The following is a description of a gene set: Ketotic hypoglycemia Low blood glucose is accompanied by elevated levels of ketone bodies in the body. Human Gene Set: HP_KETOTIC_HYPOGLYCEMIA species: Homo sapiens, and this is the list of marker genes: NNT, HNF1A, MRAP (melanocortin 2 receptor accessory protein), ACADS, MRPL39, GYS2, TXNRD2 (NCBI Gene Id 10587), PHKB, MC2R (melanocortin 2 receptor), SLC16A1, STAR (steroidogenic acute regulatory protein), ACAD8